The following is a description of a gene set: Genes predicted to be targets of miRBase v22 microRNA hsa-miR-1843 in miRDB v6.0 with MirTarget v4 prediction scores > 80 (high confidence targets). studied in species Homo sapiens Human Gene Set: MIR1843 from publication Chen Y, Wang X (PMID 31504780), and this is the list of marker genes: SH3RF1, AGBL1, CUL2, CAPN6, LPP, HECW1, HOMER1, PEG10, CCNL1, WASF1, HGF, FILIP1L, TTI2, ATAT1, SPAG1, RBMY1F, CCL4, SMS, NMT2, ORMDL2, ITGA4, CBLB, GDPD4, TRIM41, TFAP2D, ATAD2B, C16orf46, KDM2A, BAX, CCNA1, HMGN4, VWC2, EDIL3, PRUNE2, CAPZB, LAMA1, DNAJA2, ZFP91, LMO7DN (NCBI Gene Id 730604), GALP, RSL1D1, SCAMP1, ESRRG, PEAK1, RBMY1E, RBMY1A1, DCLK1, EIF5, FUBP3, STOX2, ABHD13 (abhydrolase domain containing 13), ATP1B1, MPDU1, LMLN, MAT2B, CALM2, DLX6, SPAG17, RBMY1D, MDGA2, WNT16, CTNNA3, YTHDC1, FAM169BP, OR2H1